Given this list of marker genes Crot, Crat, Cpt1b, Cpt1a, Cpt2, Cpt1c, here is a description of the gene set: species: Mus musculus Catalysis of the transfer of an acyl group to an oxygen atom on the carnitine molecule. Mouse Gene Set: GOMF_CARNITINE_O_ACYLTRANSFERASE_ACTIVITY